Given this list of marker genes CHD3, TFCP2, SIRT2, TNF, SAP18, RAN (NCBI Gene Id 87046), SIRT7, SUMO1, SAP30, SIN3B, SMG5, SIRT3, NFKB1, SIRT6, TNFRSF1A, SIRT4, YY1, XPO1, MXD1, HDAC2, UBE2I, MAX, SMAD7, NFKBIA, MTA2, CHD4, GATA1, MBD2, HDAC7, SIN3A, FKBP3 (FKBP prolyl isomerase 3), KAT2B, HDAC6 (NCBI Gene Id 100820762), HDAC3, HDAC4, PPARG, MBD3L2, GATA2, PRMT5, NR2C1, ZFPM1, HDAC11, NCOR2, EP300, SIRT1, RBBP4, HDAC9, GATAD2B, GATAD2A, SSPOP, RANGAP1, HDAC8 (NCBI Gene Id 7492), CREBBP, STAT3, HDAC10, HDAC1, PRKACA, MBD3, SIRT5 (NCBI Gene Id 285813), NCOR1, SMURF1, RELA, RANBP2, RBBP7, HDAC5, WDR77, here is a description of the gene set: from publication Schaefer CF, Anthony K, Krupa S, Buchoff J, Day M, Hannay T, Buetow KH (PMID 18832364) Human Gene Set: PID_HDAC_CLASSI_PATHWAY species: Homo sapiens Signaling events mediated by HDAC Class I